The following is a description of a gene set: studied in species Homo sapiens Human Gene Set: DURANTE_ADULT_OLFACTORY_NEUROEPITHELIUM_SUSTENTACULAR_CELLS from publication Durante MA, Kurtenbach S, Sargi ZB, Harbour JW, Choi R, Kurtenbach S, Goss GM, Matsunami H, Goldstein BJ (PMID 32066986), and this is the list of marker genes: KRT19, LYPD2, ELF3, KRT18, GSTP1, ADH1C, CXCL8 (NCBI Gene Id 3576), CYP2A13, MT1G, TSPAN8, KRT8, UGT2A1, SEC14L3, TMT1A, S100A14, MGST1, CXCL1, LCN2, PI3, MSMB, SCGB3A1, HPGD, TMEM213, TSPAN1, CYB5A, S100P, NOS2, FAM3D, PIGR, SERPINB3, VSIG2, POR, LY6D, MUC1, MUC5AC, VMO1, CLDN10, CXCL17, TFF3, SCGB1A1 (NCBI Gene Id 7356), WFDC2, AQP5, MT3, PRSS23, PSCA, CLDN4, AGR2